The following is a description of a gene set: studied in species Homo sapiens Human Gene Set: GOBP_GERMINAL_CENTER_FORMATION The process in which germinal centers form. A germinal center is a specialized microenvironment formed when activated B cells enter lymphoid follicles. Germinal centers are the foci for B cell proliferation and somatic hypermutation., and this is the list of marker genes: ADA, NFKB2, CXCL13, MEF2C, TNFSF13B, TNFAIP3 (NCBI Gene Id 7128), UNC13D, BCL3, RC3H1, FOXJ1, BCL6, KLHL6, ADAM17, PKN1